The following is a description of a gene set: Mouse Gene Set: GOBP_REGULATION_OF_DENDRITIC_SPINE_DEVELOPMENT Any process that modulates the rate, frequency, or extent of dendritic spine development, the process whose specific outcome is the progression of the dendritic spine over time, from its formation to the mature structure. species: Mus musculus, and this is the list of marker genes: Cask, Arf1, Dtnbp1, Actr2, Psen1, Plk2, Hdac2, Itsn1, Il2, Ube3a, Mapk6, Caprin2, Cdkl5, Bhlhb9, Cfl1, Foxo6, Zmynd8 (zinc finger, MYND-type containing 8), Ppfia2, Eif4g2, Mfn1, Cpeb3, Dnm3, Nlgn1, Opa1, Dhx36, Kalrn, Asap1, Ppp1r9a, Tiam1, Ngfr, Mapkapk5, Ephb2 (Eph receptor B2), Nlgn3, Il1rapl1, Pbrm1 (polybromo 1, NCBI Gene Id 76748), Stau2, Neurl1a, Camk2b, Pafah1b1, Tsc2, Dlg5, Dnm1l, Xlr3b, Efna1, Camk1, Shank3, Apoe (NCBI Gene Id 11816), Ptprd, Baiap2, Mfn2, Rac1, Nlgn2 (neuroligin 2), Grn, Shank1, Ptprs, Fstl4, Mtor, Disc1, Crebbp, Nr3c1, D16Ertd472e, Mecp2, Llph (LLP homolog, long-term synaptic facilitation (Aplysia)), Marcks, Afdn, Caprin1, Grin3a, Actr3, Kif1a, Hnrnpk, Dbn1 (drebrin 1), Cux2, Lrp8, Mef2c, Sdk1, Dbnl, Lpar1, Reln, Ngef, Tanc2, Eef2k, Fmr1, Itpka, Pten, Arf6, Pak3, Slc30a1, Palm